Given this list of marker genes BABAM1, UIMC1, BABAM2, MPND, BRCA1, BARD1, ABRAXAS1, BRCC3, here is a description of the gene set: A protein complex that contains the BRCA1-BARD1 heterodimer, RAP80/UIMC1, BRCC3/BRCC36, BRE/BRCC45, FAM175A/CCDC98/Abraxas and MERIT40/NBA1, and specifically recognizes and binds K63-linked polyubiquitin chains present on histone H2A and H2AX at DNA damage sites. species: Homo sapiens Human Gene Set: GOCC_BRCA1_A_COMPLEX